The following is a description of a gene set: studied in species Mus musculus Mouse Gene Set: GOBP_MRNA_3_END_PROCESSING_BY_STEM_LOOP_BINDING_AND_CLEAVAGE Any mRNA 3'-end processing that involves the binding to and cleavage of a stem-loop structure. For example, histone mRNAs contain a highly conserved stem-loop sequence at the 3' end of the mRNA with a 6 base pairs (bp) stem and a 4-nt loop. The mRNA is cleaved between these two elements, after the fourth or fifth nucleotide, which is typically an adenosine., and this is the list of marker genes: Lsm10, Cpsf3, Cpsf2, Zfp473, Slbp, Lsm11